Given this list of marker genes Gng2, Gnai1, Cnr2, Ryr1, Gnat1, Mcf2l, Gnb5, Gng3, Gnat2, Gna12, Gnat3, Tirap, Gng4, Atp2a2 (ATPase, Ca++ transporting, cardiac muscle, slow twitch 2), Gnb2 (NCBI Gene Id 14693), Gng7, Gnaq, Gna11, Gng5, Ryr2, Gna14, Traf6, Gng8, Gna15, Gng11, Jak1, Gnb4, Gnas, Gnao1, Plekha4 (pleckstrin homology domain containing, family A (phosphoinositide binding specific) member 4), Gngt2, Jak2, Gng14, Gna13, Gnaz, Gnai2, Cabp1, Tgm3, Gngt1, Gnb1, Gnal, Myd88, Gnb3, Gng5c, Ank2, Gng13, Gnai3, Dtna, Gng12 (guanine nucleotide binding protein (G protein), gamma 12), Jak3 (NCBI Gene Id 16453), Gng10, here is a description of the gene set: species: Mus musculus The component of a plasma membrane consisting of gene products and protein complexes that are loosely bound to its cytoplasmic surface, but not integrated into the hydrophobic region. Mouse Gene Set: GOCC_EXTRINSIC_COMPONENT_OF_CYTOPLASMIC_SIDE_OF_PLASMA_MEMBRANE